Given this list of marker genes Drd2, Chrm5, Sct, Slc51b, Pak1, Ptger3, Acacb, Apba1, Abcb4, Nmu, Cacnb4, Htr6, Ces1d, Hrh3, Htr1b, Ces1g, Ntsr1, Trpc4, Ces1h, Drd3, Casr, Ces1e, Ces1f, Tnf, Slc9a4, Cldn2, Slc6a1, Slc22a16, Gpr39, Stard10, Umod, Nf1, Tff2, Agxt, Htr1a, Hip1r, Ces1c, Cckar, Slc51a, Slc26a7, Ces1a, Slc26a6, Nherf1, Grik1, Gabbr1, Abat, Cacna1a, Sv2a, Trh, Hrh2, Ghrl, Snx10, Best1, Ces1b, Htr2c, Kcnq1, Abcb11, Myc, P2rx7, Cckbr, here is a description of the gene set: studied in species Mus musculus The controlled release of acid by a cell or a tissue. Mouse Gene Set: GOBP_ACID_SECRETION